Given this list of marker genes PLPP6, PLA2G4E, ENPP7, SMPDL3A, NAPEPLD, PLA2G15 (phospholipase A2 group XV), ABHD16B, SMPD1, PRDX6, LIPG, LIPC, ANGPTL3, PLA2G4F, SCARB1, LDLR, SMPD3, GDPD3, IDH1, APOC1, PNPLA6, PLCB1, PLA2G6, PLA2G4C, INPP5F, PLD2, PNLIPRP2, APOC2, PLBD2, GPCPD1, ENPP2, SMPDL3B, PLA2G10, GDE1, ABHD12, ABHD12B, PRKCD, PLCG1, GDPD1, PLB1, ETNPPL, ABHD6, PNPLA7, PLA2G4B, PLA2G7, SMPD2, ENPP6, PLBD1, PLA2G4A, PLCG2, SMPD4, ABHD16A, PLA2G4D (NCBI Gene Id 283748), PLD1, PNPLA8, PLA2G5, APOA2, here is a description of the gene set: Human Gene Set: GOBP_PHOSPHOLIPID_CATABOLIC_PROCESS studied in species Homo sapiens The chemical reactions and pathways resulting in the breakdown of phospholipids, any lipid containing phosphoric acid as a mono- or diester.